Given this list of marker genes Srr, Sds, Serinc4, here is a description of the gene set: part of: Metabolism of amino acids and derivatives species: Mus musculus Reactome Pathway: Serine metabolism This event has been computationally inferred from an event that has been demonstrated in another species.<p>The inference is based on the homology mapping from PANTHER. Briefly, reactions for which all involved PhysicalEntities (in input, output and catalyst) have a mapped orthologue/paralogue (for complexes at least 75% of components must have a mapping) are inferred to the other species. electronically inferred by orthology from the curated human pathway